The following is a description of a gene set: studied in species Mus musculus A process that is carried out at the cellular level which results in the assembly, arrangement of constituent parts, or disassembly of the nuclear inner or outer membrane. Mouse Gene Set: GOBP_NUCLEAR_MEMBRANE_ORGANIZATION, and this is the list of marker genes: Brox, Chmp6, Dctn1, Tor1b, Cdk1, Ndel1, Tor1aip1, Vps4b, Plk1, Chmp1a, Spast, Nsfl1c, Tardbp, Reep3, Chmp7, Chmp2b, Chmp5, Gper1, Chmp4b, Pafah1b1, Ubxn2a (NCBI Gene Id 217379), Atr (ataxia telangiectasia and Rad3 related), Tor1a, Chmp1b, Chmp3, Nemp1, Chmp2a, Banf1, Chmp1b2, Akap8l, Vps4a, Emd, Ubxn2b, Chmp4c, Ankle2, Reep4, Tmem43